The following is a description of a gene set: Human Gene Set: GOBP_N_ACETYLGLUCOSAMINE_METABOLIC_PROCESS species: Homo sapiens The chemical reactions and pathways involving N-acetylglucosamine. The D isomer is a common structural unit of glycoproteins in plants, bacteria and animals; it is often the terminal sugar of an oligosaccharide group of a glycoprotein., and this is the list of marker genes: MGAT3, GNPDA2, CHST4, HEXB, GNE, CHST6, OGA, RENBP, NAGK, EXTL2, LARGE1, CHST3, CHST7, GNPDA1, CHST5, CHST1, CHST2, NANP, AMDHD2